The following is a description of a gene set: Human Gene Set: chr17q24 studied in species Homo sapiens, and this is the list of marker genes: SNRPGP4, ENSG00000207410, MIR634 (NCBI Gene Id 693219), ABCA5, ENSG00000298578, MIR635, PITPNC1 (phosphatidylinositol transfer protein cytoplasmic 1), PSMD12, CACNG1, RN7SL735P, MIR4524B, RGS9, RPL36AP48 (NCBI Gene Id 651209), ENSG00000252274, HELZ-AS1, MIR6080, SOX9-AS1, SH3GL1P3, LINC01482, MIR548D2, RNA5SP447, ABCA8, PRO1804, PRKAR1A, CALM2P1, LINC01028, CACNG5 (calcium voltage-gated channel auxiliary subunit gamma 5), PRKCA, SOX9, BPTF, LINC02097, SLC16A6, ABCA9, KCNJ2, ABCA6, RNA5SP444, PSMD7P1, ENSG00000290052, CASC17, BPTFP1, LRRC37A3, FBXO36P1, RPSAP67, AMZ2P1, SEC24AP1, SLC16A6P1, RNU7-155P, RPL32P33, RNA5SP446, RN7SL622P, ABCA10 (ATP binding cassette subfamily A member 10), SNORA38B, SMURF2, KCNJ2-AS1, ARHGAP27P2, LRRC37A16P (leucine rich repeat containing 37 member A16, pseudogene), MYL6P5, LINC00674, RN7SKP180, ARSG, LINC02003, ENSG00000288109, PRKCA-AS1, CACNG4, KPNA2, MIR548AA2, RNU7-115P, LINC00511, RNU6-928P (RNA, U6 small nuclear 928, pseudogene), RDM1P4, GNA13, APOH, C17orf58, LINC01483, RN7SL404P, ENSG00000263893, AXIN2, KCNJ16, RPL17P41, LINC02563, NOL11, FAM20A, LINC01497, MIR4315-2, KPNA2P3, RNA5SP445, RN7SL756P, WIPI1, PLEKHM1P1, ROCR, HELZ, ENSG00000265055, MIR4524A, CEP112, MICOS10P2, AMZ2, ABCA9-AS1, MAP2K6, LINC01152, RDM1P3, ARHGAP27P1-BPTFP1-KPNA2P3, ENSG00000303200